Given this list of marker genes BIVM (NCBI Gene Id 54841), TRIM71, SAMD13, DNMT3A, WIZ, CHRM2, TBL1XR1, ADAMTS6, NFIX, MYPN (myopalladin), MGAT5, PTGFRN, CPE, MAP3K20, PIEZO2, LRRN1, ZNF692, TMEM87A, GRID2, PCGF5, KLHL29, FHOD3, TMEM132C, DSG1, BLOC1S5, NAV2, NRSN1, BHMT, NFYC, CREBRF, LRP12, TSKU, YIPF4, COA7, PURA, DCX, CDH19, MFHAS1, ANKS1B, BRWD3, FGD4, PAN3, FAM177A1, CHRNA3, PNLIPRP3, PKIB, SRSF1, UBR2, TRPV1, RRAGD, UBASH3B, MTMR10, ERRFI1, GID4, CHTF8, CHST6, ZNFX1, TMED10, TRMT2B, SAMD7, NIP7, NUMB, CXXC4, SLC39A5, NUFIP2, ZNF616, ATXN7L1, PECR, EPHA5, AFG1L, FARP2, here is a description of the gene set: Genes predicted to be targets of miRBase v22 microRNA hsa-miR-6772-3p in miRDB v6.0 with MirTarget v4 prediction scores > 80 (high confidence targets). Human Gene Set: MIR6772_3P studied in species Homo sapiens from publication Chen Y, Wang X (PMID 31504780)